The following is a description of a gene set: from publication Konuma T, Nakamura S, Miyagi S, Negishi M, Chiba T, Oguro H, Yuan J, Mochizuki-Kashio M, Ichikawa H, Miyoshi H, Vidal M, Iwama A (PMID 21540074) species: Homo sapiens Human Gene Set: GSE27786_LSK_VS_NKTCELL_DN Genes down-regulated in comparison of LSK versus NKT cells. Each fraction of mouse hematopoietic cells was purified by cell sorting from bone marrow of 8-week-old C57BL/6 mice, and its gene expression was analyzed., and this is the list of marker genes: RNF138, NMB, RCBTB2, NR3C1, ST8SIA3, SHLD1, PLEKHF1, IST1, PSMD14, CRHR1, INHBA, SLC37A3, PRSS41, COX16, KLRC2, ANKRD11, EN1, GLG1, MAP3K3, THOC2, PTPN6 (NCBI Gene Id 5777), CD177, CFHR2, RAB2A, CHD8, RPL23A, PRKD3, DUSP7, DQX1, HSD11B2, F2RL1, AQR, UBXN11, TMA7, LENG9, MYO1E, PON2, ADH1C, TMTC4, MARK3, GPR183, EZH1, MIA3, SRA1, USP24, SLC16A6, TEKTL1, PRSS46P, GTPBP2, PPP2R5A (NCBI Gene Id 5525), WASHC2A, USP34, CD27, CRISPLD2, KRT81, NRDC, LRCH1, CPSF3, RANBP10, PRMT9, AGFG1, SHARPIN, GPNMB, CNDP2, RPL18, SURF1, SKOR1, FLNA, CSTA, RIT1, GPX3, IL21R, FHIP2B, ZBTB8OS, TAF12, DHPS, MED12, WNT2, DPT, IL17RD, PSMC2, UBL4A (NCBI Gene Id 8266), BBS9, LAPTM5, MRAP2, HLTF, FIS1, TNFSF14, AP1M2, WDR91, TWF2, PTCRA, IQSEC1, RTRAF, PSENEN, JARID2, F2RL2, TMEM63A, TENT5A, PCBD2, MED30, TMEM161B, NCALD, GPR65, CCDC88B, LYPD6B, TRAF2, AKR1B1, CRNKL1, SGSH, PPIA, SSU72, TNKS2, SYT3, COL22A1, ANKRD13D, LIMD1, ACTR2, AGO2, RPL31, RALGAPB, RPS25, RACK1, BLVRA, ZNF274, ETV4, MRPS15, PIWIL2, DAPK2, YWHAZ, PSMA3, PDLIM1, PLEKHA5, RIGI, CCDC102A, PDCD4, IRF2BPL, TRIR, SNF8, PSMB10 (proteasome 20S subunit beta 10), MBP, SMDT1, NABP1 (NCBI Gene Id 64859), SLC25A46 (solute carrier family 25 member 46), PRRT1, RPL36, SNX1, PEDS1, IKBKE, CYSLTR2, TASP1, KRTCAP3, WDR26, MYO1H, METTL26, CHD3, SUN2, DEDD, MEF2B, SLC4A1, DPF3, YPEL5, AIP, OR51E1, SVIL, SESN3, C1orf52, EVA1C, KDM4D, IFI30, CEMIP, LSM14A, S1PR1, REX1BD, PHKG2, ARAP3, KLHL25, MTARC2, DPP6, ASXL2, RAP1A, DNAJC17, NFKBIE, FLII, KRT222, EIF4A2, SLC2A8, HERPUD2, CD72, WHAMM, HECTD3, BCL2L10, HDHD5, ATP6AP1, KCNG4, SUSD6, JHY, PGLYRP1